Given this list of marker genes IKBKB, ITGB1BP1, ARHGAP6, THBS1, TNF, ACE, DLC1, DUSP22, SRC, SLIT1, ROCK2, PTPN13, CBLN1, ROCK1, PHLDB2, RPS6, CORO1C, MIR142, CLASP2, RCC2, DMTN, EPHA7, CLSTN3, ACVRL1, FAM107A, PTEN, WNT5A, DKK1, TLR2, APOD, ROBO2, IL1B, MIR105-1, MMP14, here is a description of the gene set: Human Gene Set: GOBP_NEGATIVE_REGULATION_OF_CELL_JUNCTION_ASSEMBLY species: Homo sapiens Any process that stops, prevents or reduces the frequency, rate or extent of cell junction assembly.